Given this list of marker genes PSMB10, FOXN1, NSMCE3, KNSTRN, IL2RG, MGAT2, CARD11, ZAP70, CD27, LIG1, RAC2, RFXANK, CTPS1, LCP2, CD247, PGM3, TNFRSF9, RFXAP, IL7R, LAT, IL2RA, MALT1, STAT1, DEF6, PIK3CD, SYK, CD3D, RAG1 (NCBI Gene Id 5896), TGFB1, IKBKB, RASGRP1, REL, EXTL3, RAG2, JAK3, CD3E, RNF31, RFX5, PNP, WIPF1, MRTFA, DOCK2, CIITA, SLF2, MCM10, here is a description of the gene set: Abnormal cell proliferation Human Gene Set: HP_ABNORMAL_CELL_PROLIFERATION species: Homo sapiens Any abnormality in the multiplication or reproduction of cells, which may result in the expansion of a cell population.